Given this list of marker genes LEP, SOCS3, STAT3, IRS1, IRS2, STAT5B (NCBI Gene Id 6777), SH2B1, LEPR, PTPN11, STAT5A, JAK2, here is a description of the gene set: Human Gene Set: REACTOME_SIGNALING_BY_LEPTIN Signaling by Leptin species: Homo sapiens